The following is a description of a gene set: Any process that stops, prevents, or reduces the frequency, rate or extent of the addition of telomeric repeats by telomerase. studied in species Mus musculus Mouse Gene Set: GOBP_NEGATIVE_REGULATION_OF_TELOMERE_MAINTENANCE_VIA_TELOMERASE, and this is the list of marker genes: Dcp2, Pot1b, Hnrnpu, Terf2, Tent4b, Gnl3l, Hnrnpc, Stn1, Ten1, Pif1, Terf1, Trp53, Pot1a, Ctc1, Exosc10, Tinf2, Pml, Src (Rous sarcoma oncogene), Nat10, Acd, Pinx1